Given this list of marker genes IFNA17, IFNB1, IFNK, IFNA14, IFNA6, IFNA7 (interferon alpha 7), IFNA16, IFNA5, IFNA4, IFNA1, IFNA8, IFNE, IFNW1, IFNA21, IFNA10, IFNA2, here is a description of the gene set: studied in species Homo sapiens Human Gene Set: GOMF_TYPE_I_INTERFERON_RECEPTOR_BINDING Binding to an interferon-type I receptor, a heterodimeric complex composed of an alpha subunit (IFNAR1) and a beta subunit (IFNAR2).